Given this list of marker genes CASP9, LRRK2, APAF1, CASP3, CYCS, here is a description of the gene set: Human Gene Set: KEGG_MEDICUS_VARIANT_MUTATION_ACTIVATED_LRRK2_TO_INTRINSIC_APOPTOTIC_PATHWAY studied in species Homo sapiens Mutation-activated LRRK2 to intrinsic apoptotic pathway. Pathway ID: N01047. Pathway type: Variant. Pathway class: nt06463 Parkinson disease. Pathway Definition from KEGG: LRRK2* -> CYCS == APAF1 -> CASP9 -> CASP3